The following is a description of a gene set: Human Gene Set: HP_ABNORMAL_SELLA_TURCICA_MORPHOLOGY Abnormality of the sella turcica, a saddle-shaped depression in the sphenoid bone at the base of the human skull. Abnormal sella turcica morphology species: Homo sapiens, and this is the list of marker genes: GUSB (NCBI Gene Id 2990), SUFU, SLC17A5, NOTCH2, LHX4, NR3C1, NAA10, BRAF, PCNT, TBC1D2B, PLOD3, TP53 (tumor protein p53), MAN2B1, USP48, ZSWIM6, TSHB, DNA2, PTCH1, FLNA, GNPTAB, ATRX, USP8 (ubiquitin specific peptidase 8), TRIM37, PTCH2, SOST, OBSL1, VPS33A, ABCC9, BMP4, RMRP, NKX2-1, IDUA, AEBP1, ALDH18A1, ADAMTSL2, DYM, MAF, CDH23, MTX2, POP1, STUB1, CDH11, GLB1